The following is a description of a gene set: species: Homo sapiens Inhibition of replication initiation of damaged DNA by RB1/E2F1 Human Gene Set: REACTOME_INHIBITION_OF_REPLICATION_INITIATION_OF_DAMAGED_DNA_BY_RB1_E2F1, and this is the list of marker genes: POLA2, TFDP2, PPP2CB, PPP2R1A, PPP2CA, PRIM2, E2F1, PPP2R1B, POLA1, PPP2R3B, PRIM1, TFDP1, RB1